The following is a description of a gene set: studied in species Homo sapiens Human Gene Set: HALLMARK_XENOBIOTIC_METABOLISM Genes encoding proteins involved in processing of drugs and other xenobiotics. from publication Liberzon A, Birger C, Thorvaldsdóttir H, Ghandi M, Mesirov JP, Tamayo P (PMID 26771021), and this is the list of marker genes: SLC22A1, SAR1B, DDC, EPHA2 (NCBI Gene Id 1969), BPHL, GART, PTGDS, GCNT2, AOX1, GSTA3, ENPEP, IGFBP4, ASL, ACSM1, KARS1, PINK1, ANGPTL3, CYP2J2, ACO2, TGFB2, ACOX3, GAD1, HRG, DHRS7, BLVRB, PMM1, RBP4, ARG1, NQO1, DDT, ACP1, MAN1A1, TYR, MT2A, TTPA, SHMT2, TDO2, FMO3, LONP1, MPP2, TPST1, POR, CYB5A, UPB1, TNFRSF1A (NCBI Gene Id 8077), CYP2C18, CSAD, CYP1A2, LCAT, MAOA, SLC6A6, PSMB10, SERPINA6, CYP1A1, CBR1, ACOX1, SLC1A5, ECH1 (enoyl-CoA hydratase 1), ALAS1, ESR1, ACOX2, CYP2S1, CYFIP2, DDAH2, ALDH3A1, SLC35B1, AP4B1, ACP2, ID2 (inhibitor of DNA binding 2), GSTM4, G6PC1 (NCBI Gene Id 2538), CDO1, NMT1, GABARAPL1, GSR, ABHD6 (abhydrolase domain containing 6, acylglycerol lipase), IDH1, ETS2, PDLIM5, ARPP19, FABP1, TMEM97, SPINT2, AHCY, RETSAT, TAT, F10, PDK4, FMO1 (flavin containing dimethylaniline monoxygenase 1), ABCC3, AKR1C3, IGFBP1, PTGR1, VNN1, ELOVL5, ALDH9A1, ITIH1, VTN, HGFAC, TKFC, FAS, ATP2A2, CA2, TMBIM6, SMOX, ADH5, NFS1 (NFS1 cysteine desulfurase), SERPINE1, REG1A, CYP2E1, CES1, BCAR1, FAH, CDA, PGD (NCBI Gene Id 5226), IGF1, SLC46A3, GSS, ITIH4, CRP, SSR3, CYP17A1, CAT, NINJ1, GNMT, CD36, GSTT2, ATOH8, DHRS1, SLC35D1, PYCR1, APOE, PTS, CFB, NPC1, MARCHF6, FBP1, ADH7, JUP, UGDH, BCAT1, ALDH2, ABCC2, PTGES3, ABCD2, CNDP2, GCKR, AQP9, MBL2, RAP1GAP, ENTPD5, UPP1, PROS1, PEMT, LEAP2, CYP27A1, CROT, COMT, PAPSS2, PLG, PGRMC1, MCCC2, LPIN2, GCLC, MTHFD1, XDH, NDRG2, F11, ETFDH, AKR1C2, SLC6A12, FBLN1, GCH1, CYP4F2 (NCBI Gene Id 8529), PPARD, KYNU, HSD11B1, HSD17B2, CCL25, GSTO1, HPRT1 (NCBI Gene Id 3251), HNF4A, PTGES, HMOX1, IRF8, SERTAD1, IL1R1, DHPS, PC, DCXR, SLC12A4 (NCBI Gene Id 6560), EPHX1, TMEM176B, CYP26A1, FETUB, ARG2, CASP6, HACL1, ADH1C, HES6